The following is a description of a gene set: Human Gene Set: GOMF_GLYCINE_BINDING Binding to glycine, aminoethanoic acid. species: Homo sapiens, and this is the list of marker genes: GLRA1, GLRA2, GRIN3A, GRIN3B, GRIN2B, GLRA3, GRIN1, SRR, GLRB, GLDC, GNMT